Given this list of marker genes LY6D, GPSM2, NCK2, ETS2, TIFA, PLD3, SPCS2, CARD10, GLCCI1, BLVRA (biliverdin reductase A), PSMB2, GATA1, ATP1B1, AURKA, SLAMF6, SYTL3, NCKAP1, SEMA4A, DNAJC7, PLA2G12A, THNSL2, ARPP21, KAT7, LEF1, C18orf32, NEK2, CTLA4, H19, DDAH2, CDC25B, H2AZ1, ART4, LCK, EPB41L4B, THY1, MS4A1, C1QTNF1, CD3D, AXIN2, FBXL12, MCUB, MPZL2, BRMS1, ATP8A1, EDARADD, PSMB5, PRNP, ZW10, RAB40B, TK1, EXOSC2, PIMREG, CAP1, CDKN2D, HPCAL1, RRM2, NRF1 (NCBI Gene Id 4899), UBL4A, SIT1, HIBADH, CLDN2, TUBB2B, CD3G, COL3A1, SMOX, ADRA2B, BCAT1 (NCBI Gene Id 586), PRKCA, DNAI4, C3orf70, MTHFD2, ACP5, IL2RA, PPT1, GCOM1, TM7SF2, DGKE, SYTL2, CD96, MOG, PTPN13, NOTCH3, GINS4, JAM2, CASP6, LAMB3, TNFAIP8L1, PLPP1, IKZF4, RAD18, SLAMF1, TKTL1 (transketolase like 1), ITPR2, PPIC, PBK, DYSF, SOCS2, FKBP5 (FKBP prolyl isomerase 5), IRAG2, EPCAM, IL17RB, DHX40, PCLAF, EDEM1, ACADL, DERA, PKP3, RPS6KB2, CENPO, LPXN (leupaxin), CCND3, OSTC, PSMC3IP, CDKN2C, PRKCQ (protein kinase C theta), ELAVL3, PLXDC2, TM9SF1, GRAP2, MIF4GD, TMEM242, CDK5RAP3 (CDK5 regulatory subunit associated protein 3), RTKN2 (rhotekin 2), RAG1, B3GNT2, GABARAPL2, LGALS1, DMC1, PCCB, BHLHE40, MYL10, PTPRF, CDON, LAT, MAD2L1, CENPA, KIF4A, CCT7, ANGPTL2, RRM1, DTNBP1, PMEPA1, PITHD1, SUPT4H1, DNAJC24, TMEM97, MPP4, HMGCS2, TCF12, GZMA, KIFC3, TEDC1, ESM1, CPA3, COX14, GBP6, AARSD1, HSD11B1, ANXA2, MS4A6A, RFXAP, TMEM191C, INSL5, IL7R, MYL11, ITK, ENDOU, ENTPD5, TUBA8, FLT3LG, IFNGR1, KHDC1L, TMPO, PLK1, BCL11B, ASCL3, ARMT1, DGKA, ASF1B, CCNA2, CD247, SEC24D, PPARG, MORC1, RPL3L, RRAS2, STARD3NL (STARD3 N-terminal like), DNAJC9, DDC, RHOH, SKA1, SLC35D1, CDKN1A (NCBI Gene Id 1026), GSR, DESI1, MPP1, RAD54L, TMEM120B, SH2D1A, NEFH, here is a description of the gene set: Genes down-regulated in comparison of adult thymic progenitors versus adult DN2 thymocytes. Human Gene Set: GSE24142_EARLY_THYMIC_PROGENITOR_VS_DN2_THYMOCYTE_ADULT_DN from publication Belyaev NN, Biró J, Athanasakis D, Fernandez-Reyes D, Potocnik AJ (PMID 22581009) Development of T-cells provides a unique opportunity to study cell-fate determination due to the accessability and the well defined stages of developmental stages. In order to understand the genetic programs underlying fetal and adult T‑cell fate specification we subjected highly purified fetal and adult T-cell progenitor populations to a genome‑wide transcriptional analysis. The aim was to identify molecular elements that govern T-cell fate specification as a whole but ultimately to isolate elements that were specific for a given population in a specific developmental window. studied in species Homo sapiens